The following is a description of a gene set: Human Gene Set: GOBP_PRIMITIVE_ERYTHROCYTE_DIFFERENTIATION Erythrocyte differentiation which occurs as part of the process of primitive hemopoiesis. species: Homo sapiens, and this is the list of marker genes: HSCB, ZFPM1, VEGFA, GATA1, GATA2